Given this list of marker genes Strap, Cyp26c1, Cyp26b1, Plpp6, Bco2, Cyp26a1, Sp1, Cyp2w1 (cytochrome P450, family 2, subfamily w, polypeptide 1), Klf9, Akr1c18, here is a description of the gene set: The chemical reactions and pathways resulting in the breakdown of terpenoids, any member of a class of compounds characterized by an isoprenoid chemical structure. Mouse Gene Set: GOBP_TERPENOID_CATABOLIC_PROCESS studied in species Mus musculus